Given this list of marker genes Cpeb3, Cpeb2, Cpeb4 (cytoplasmic polyadenylation element binding protein 4), Dhfr, Rara, Paip2, Shmt1, Tyms, Cpeb1, Pura, Paip2b, Purb, here is a description of the gene set: Antagonizes the ribosome-mediated translation of mRNA into a polypeptide via direct binding (through a selective and non-covalent interaction) to nucleic acid. Mouse Gene Set: GOMF_MRNA_REGULATORY_ELEMENT_BINDING_TRANSLATION_REPRESSOR_ACTIVITY species: Mus musculus